Given this list of marker genes Hyal2, Hexb, Cd44, Lyve1, Slc9a1, Hyal1, Hyal3, Hmmr, Gusb, Chp1, Stab2, Hexa, here is a description of the gene set: species: Mus musculus Mouse Gene Set: REACTOME_HYALURONAN_UPTAKE_AND_DEGRADATION Hyaluronan uptake and degradation